Given this list of marker genes GUCY1A2, CNOT6L, ZNF326, ZBTB10, SAMHD1, FLI1, SNAPC3, CUL2, NRARP, NPY2R, CEP135, TPK1, KGD4, ZFAND4, ZBTB6, BTN3A3, TENM1, CHSY3, STRIP2, DYNC1LI2, GTPBP10, SLC26A4, SIVA1, TNFAIP1, CCDC122, RERE, SIRT4, RIMS1, CNTNAP3, CTCFL, PPARGC1A, ENOX1, SIX1, PIAS3, NFIB, PCDH9, PSMC6, OTUD6B, KIDINS220, PTPRG, ZC3H14, TICAM2, LRRFIP2, NFS1, RGPD5, CHST9, WBP2NL, GNAI1, TDG, CPEB4, TTC7B, CACYBP, RGPD3, P4HA1, RGPD6, MINDY2 (MINDY lysine 48 deubiquitinase 2), TMEM242, EPHB1, LPCAT1, NR4A1, MARCHF1 (NCBI Gene Id 55016), ZC3H12D, CD46, HIRA, ZBTB24, RGPD4, MOSPD2, CHCT1, ZNF665, SEC23IP, MASP1, LMO2, FRG2, PPFIA1, C5orf24, ZNF684, FKBP7, SFMBT1, RNF169, TFRC, SCPEP1, FRG2C, TEAD1, GNA12, GCC2, GRID1 (NCBI Gene Id 54547), ADAM22, BCL2L10, SPC24, SELE, RGPD8, SULF1, DMD, TBL1XR1, CFAP418, ZRANB3, SLC9A2, WDR43, KCNH8, SFXN1, UBE2B, XKR4, MIX23, CEP44, USP9Y, PRR11, FAM168A, GPATCH2L, TMED7-TICAM2, PTER, SLC26A3, CNTNAP3B, EIF4H, GLYATL2, FAM98C, ZNF780B, LRRC23, HMBOX1, SGMS2, ATP8A2, C7, PDE8B, SFMBT2, TRIQK, PTCHD1, SLC9B1, NEGR1, OPN5, NCL, GLRA2, ENPP2 (ectonucleotide pyrophosphatase/phosphodiesterase 2), EREG, ARIH1, RNF103 (NCBI Gene Id 7844), TMPRSS5, MAMLD1, SLC25A36, METTL15, LRFN5, here is a description of the gene set: Human Gene Set: MIR215_3P species: Homo sapiens Genes predicted to be targets of miRBase v22 microRNA hsa-miR-215-3p in miRDB v6.0 with MirTarget v4 prediction scores > 80 (high confidence targets). from publication Chen Y, Wang X (PMID 31504780)